Given this list of marker genes Slc30a1, Abcb6, Slc39a8, Mt3, Slc11a1, here is a description of the gene set: Any process that reduces or removes the toxicity of cadmium ion. These may include transport of cadmium away from sensitive areas and to compartments or complexes whose purpose is sequestration of cadmium ion. studied in species Mus musculus Mouse Gene Set: GOBP_DETOXIFICATION_OF_CADMIUM_ION